Given this list of marker genes ADIPOQ, GDF6, PDGFA, PDGFRB, PDGFB, here is a description of the gene set: studied in species Homo sapiens Human Gene Set: GOBP_CELL_MIGRATION_INVOLVED_IN_METANEPHROS_DEVELOPMENT The orderly movement of a cell from one site to another that will contribute to the progression of the metanephric kidney over time, from its formation to the mature organ.